Given this list of marker genes SESN2, ULK1, ATG101, TBC1D5 (NCBI Gene Id 9779), C9orf72, SMCR8, ATG13, RB1CC1, here is a description of the gene set: studied in species Homo sapiens A protein complex consisting of Atg1 (or Atg1 homologs e.g. ULK1, ULK2 in mammals) and Atg13 along with other proteins that regulate its function (e.g. Atg17 in yeast or RB1CC1(FIP200) in mammals). This complex has serine/threonine protein kinase activity and is involved in autophagosome formation. Human Gene Set: GOCC_ATG1_ULK1_KINASE_COMPLEX